Given this list of marker genes APH1A, B2M, NPPA, UBC, MFGE8, SAA1, H4C15, H2BC12L, H2BC6, H4C9, LTF, APOE, H4C13, BACE1, H4C11, CALB1, H2BC8 (H2B clustered histone 8), UBA52, H2AC4, CALCA, USP9X, SEMG1, GGA3, TGFBI, H3C2, H2BC1, H4C14, H3C15, H2BC7, H2BC4, H3C13, ADAM10, H2BC9, FGA, H2AC6, INS, H2BC11, SIAH1, H2AZ1, H3-3B, SORL1, H3C8, H4C4, TSPAN5, H2AX, RPS27A, H2AC18, H2BC3, UBE2L6, H2BC13, H3C6, H4C5, H3C11, HSPG2, H4C6, H2BC26, FURIN, LYZ, SNCA, H3C10, H3C14, NAT8, H2AC8, H4C8, H2BC10, H2AB1, SNCAIP, UBB, H3C3, PRKN, SIAH2 (siah E3 ubiquitin protein ligase 2), H4C2, H2BC5, APP, H3C1, H2AC20, APOA4, CST3, H2BC17, H4C12, GGA2, H4C3, H4C1, ITM2B, H2BC12, TSPAN33, PRL, H4C16, H2AC7, H3C4 (NCBI Gene Id 8351), H2AC14, TSPAN15, NCSTN, H3C7, ODAM, IAPP, H2AC19 (NCBI Gene Id 723790), PSENEN, GSN, H3-3A, H2BC21, APOA1, APH1B, H3C12, APCS, TSPAN14, H2BC15, TTR, GGA1, H2BC14, here is a description of the gene set: Human Gene Set: REACTOME_AMYLOID_FIBER_FORMATION Amyloid fiber formation species: Homo sapiens